Given this list of marker genes mt-Co1, Ndufs1, Ndufs3, Cyb561d1 (cytochrome b-561 domain containing 1), Ndufs2, mt-Nd4l, Ndufa10, Uqcrh-ps1, mt-Nd5, Cox7a1, Uqcrh, Cox5a, mt-Nd6, Cyc1, Cox4i2, Ndufs7, mt-Nd3, Ndufs8, Cybrd1, mt-Nd2, Ndufa2, mt-Nd4, Nnt, Ndufv1, mt-Co3, mt-Nd1 (NCBI Gene Id 78300), Uqcrfs1, mt-Cytb, Ndufs4, mt-Co2, Ndufv2, Cyb561a3, Ndufb7, Surf1, Cyb561d2, here is a description of the gene set: Primary active transport of a solute across a membrane, driven by exothermic flow of electrons from a reduced substrate to an oxidized substrate. Primary active transport is catalysis of the transport of a solute across a membrane, up the solute's concentration gradient, by binding the solute and undergoing a series of conformational changes. Transport works equally well in either direction and is driven by a primary energy source. species: Mus musculus Mouse Gene Set: GOMF_OXIDOREDUCTION_DRIVEN_ACTIVE_TRANSMEMBRANE_TRANSPORTER_ACTIVITY